Given this list of marker genes Inha, Igsf1, Acvr2b, Acvr1b, Acvr2a, here is a description of the gene set: studied in species Mus musculus Binding to an inhibin monomer, any of the polypeptides that combine to form activin and inhibin dimers. Mouse Gene Set: GOMF_INHIBIN_BINDING